Given this list of marker genes Kat5, Cep295, Xbp1, Ddx3x, D1Pas1, Pml, Ep300, Prkaa2, Sox4, Prkaa1, Dip2b, Nfe2, Bmal1, Fam161a, Arid5a (NCBI Gene Id 214855), Taok1, Dip2a, here is a description of the gene set: species: Mus musculus Any process that activates or increases the frequency, rate or extent of protein acetylation. Mouse Gene Set: GOBP_POSITIVE_REGULATION_OF_PROTEIN_ACETYLATION